Given this list of marker genes WDR45, ACTN2, SNX3, KCNJ2, PLA2G4A, TWF2, CGAS, TPCN1, LDLRAP1, KCNQ1, KCNJ3, PLEKHA5, ADAP1, DEFB4A, ZFYVE28, SVIL, RNF34, WDR45B, RUBCNL, SNX12, WASHC2A, KRIT1, TULP1, PLCD1, KCNH1, DENND1C, MAPKAP1, SYT9, AVIL, TIRAP, JPH2, ARHGAP32, VEPH1, PLCB1, SNX27, SNX4, CLVS1, DNM2, DENND1A, PLEK2, SCIN, RCSD1, FZD7 (frizzled class receptor 7), MAPT, FCHO2, OSBP, OBSCN, PIRT, SNX24, TWF1, CYTH3, RUFY4, KCNJ1, PLEKHF1, PLEKHN1, BBS5, PHLDA2, ALOX15, OSBPL5, PLEKHA3, SNX22, PLEKHA8, SYT10, ARAP3, OSBPL2, PARD3, ATG2B, SNX14, LAPTM4B, TTPAL, ARHGAP9, COMMD1, ARFIP1, ZFYVE19, DENND1B, SH3PXD2A, SNX20, HIP1, GRAMD2A, FCHSD2, SNX13, PLEKHA4, LANCL2, SDCBP, MYO1B, VIL1, SYT7, TOM1, VILL, GBF1, RUBCN (NCBI Gene Id 9711), RLBP1, PHLDA3 (pleckstrin homology like domain family A member 3), CFL1, CERT1, AMER2, AMER1, SDCBP2, PFN2, RPH3A, SYT1, ZFYVE26, ATG2A, CLVS2, AMER3, GSN, NLRP3, ANXA2, FGD2, GOLPH3L, ATP13A2, TECPR1, GSDMB, ARFIP2, IQGAP1, VPS36, DAPP1, OGT, PICALM, SNX18, ANKFY1, FRMPD4, SNX11, FERMT2, NRGN, GAP43, AKT1, GSDME, MYO10, NCF4, KIF16B, SLC9A1, MTSS2 (MTSS I-BAR domain containing 2), SNX21, PLA2G4E, WIPI2, DNM1, IQGAP2, CAPG, WASHC2C, SNX19, TTPA, RBSN, ARAP2, PLEKHB2, HCN1, SYT5, SNAP91, ADAP2, TULP3, MARK1, CHMP3, MYO1G, GSDMD, GSDMC, ANXA8, HIP1R, TPCN2, GAB2, SNX10, RAB35, OSBPL8, RACGAP1, DAB2IP, SH3PXD2B, PFN1, BTK, RAG2, ARAP1, TRPM3, GSDMA, EXOC7, PHLDA1, FUNDC2, SNX5, ZFYVE16, EXOC1, SESTD1, ZFYVE1, WIPI1, SYTL2, VPS13B, SAP30L, PLCZ1, GOLPH3, FLII, here is a description of the gene set: species: Homo sapiens Human Gene Set: GOMF_PHOSPHATIDYLINOSITOL_PHOSPHATE_BINDING Binding to phosphatidylinositol phosphate.